The following is a description of a gene set: species: Homo sapiens Genes down-regulated in CD4 Th1 cells: control versus anergic. Human Gene Set: GSE46242_TH1_VS_ANERGIC_TH1_CD4_TCELL_DN from publication Zheng Y, Zha Y, Spaapen RM, Mathew R, Barr K, Bendelac A, Gajewski TF (PMID 23548837) T cell anergy is one of the mechanisms contributing to peripheral tolerance, particularly in the context of progressively growing tumors and in tolerogenic treatments promoting allograft acceptance. We recently reported that early growth response gene 2 (Egr2) is a critical transcription factor for the induction of anergy in vitro and in vivo, which was identified based on its ability to regulate the expression of inhibitory signaling molecules diacylglycerol kinase (DGK)-a and -z. We reasoned that other transcriptional targets of Egr2 might encode additional factors important for T cell anergy and immune regulation. Thus, we conducted two sets of genome-wide screens: gene expression profiling of wild type versus Egr2-deleted T cells treated under anergizing conditions, and a ChIP-Seq analysis to identify genes that bind Egr2 in anergic cells. Merging of these data sets revealed 49 targets that are directly regulated by Egr2. Among these are inhibitory signaling molecules previously reported to contribute to T cell anergy, but unexpectedly, also cell surface molecules and secreted factors, including lymphocyte-activation gene 3 (Lag3), Class-I-MHC-restricted T cell associated molecule (Crtam), Semaphorin 7A (Sema7A), and chemokine CCL1. These observations suggest that anergic T cells might not simply be functionally inert, and may have additional functional properties oriented towards other cellular components of the immune system., and this is the list of marker genes: SNAPC2, LINC01426, ZCWPW2, CD24, ZNF568, ULK2, ARHGAP11A, OR10R2, NPIPA1, SMAD1, MYO1H, IL7R, RERE, TMCC3, GPAT3, SEMA3E, HCAR3, FBXL16, TUBG2, TCHH, MELK, NRCAM, DDX18, PEPD, FBXO36, GLYATL2, CLEC12B, GNG7, EXO5, RFXAP, TAS2R16, ARPIN, ENSG00000236854, MCCC1, FKBP11, DOCK1, SART1, MAP3K13, AGBL1, BAP1, RNF182, INS, NEUROD4, ZNF532, MIR214, FKBP5, POM121L8P, RAI2, ACAN, DUSP5, SYT16, RAB30, HYLS1, H2BC6, OSMR, JADE3, USP53, CTTNBP2, BTF3P11, AMIGO3, KLHL32, GNL3, FAM110A, SLC34A2, WASF1, IRF7, GSTM4, NFXL1, DGKZ, RGS2, KIAA1671, CAMK1G, LINC01020, STRBP, NAGPA, RYR1, VGLL3, ZNF14, RSBN1L, ZDHHC11, PNLIPRP3, PMS2P4, NCOR2, C15orf39, CNTLN, GDI2, TEX36, PRPH, CMPK2, LCE1B, SPTLC3, PHLDA2, EOLA1-DT, TMEM174, CES5A, RPTN, OR2W3, ABCA2, RPRD2, MOBP, SCARNA15, TUG1, FOXP4, ADH1A, TAPT1, NDUFA12, CD151, DCX, ADORA2B, CASTOR3P, RHCE, TEX46, ADAMTS20, GRSF1, RBM10, ZNF544, KCNK2, CUL9, LINC02487, ZNF384, PGBD4, SBNO2, UNC45A, CDC42BPA, UMODL1, TMEM237, KRT12, CASQ1, FOXP1, MPZL3, FLOT2, ACTN4, OR2A4, LINC00240, MAN2A2, TBC1D17, RNPEPL1, SH2D4A, PRPF38A, FHOD1, GATB, ADAM20, LINC02112, RETREG3, TM4SF18, G6PC1, BCL10-AS1, PTHLH, CD1A, NPFFR2, CELF4, PALD1, FAIM2 (Fas apoptotic inhibitory molecule 2), SNTN, ATP10B, ZNF484, PDC, PHLDB2, IL1RAP, GYPA, HPS1, TIMM44, TBL1X, RAB15, ZNF641, ACOT6 (acyl-CoA thioesterase 6), ALLC, ZNF580, MAMDC4, GSG1, CEP112, ARPC5L, AGRN, DMBX1, ENTREP1, SDHC (NCBI Gene Id 6391), FMO6P, CLEC4C, DEPDC1, EMID1, KIF25, ZFP37, MYCT1, TAFA4, AMN1, H2BC5, PSTPIP2, FANCD2, MAN1C1, RAB7A, BEND7, NPY2R, FOXJ2